The following is a description of a gene set: Cellular response to mitochondrial stress Mouse Gene Set: REACTOME_CELLULAR_RESPONSE_TO_MITOCHONDRIAL_STRESS studied in species Mus musculus, and this is the list of marker genes: Yme1l1, Eif2ak1, Stoml2, Dele1, Phb2, Oma1, Eif2s1, Eif2s3x, Eif2s2